The following is a description of a gene set: species: Homo sapiens Human Gene Set: GOBP_OBSERVATIONAL_LEARNING Learning that occurs through observing the behavior of others., and this is the list of marker genes: NRXN1, FOXP2, KIAA0319, CNTNAP2, HTT, NRXN2, STRA6, SHANK3, NF1